Given this list of marker genes Glcci1, Hipk2, Rgs7bp, Smarca1, Cd3g, Apbb2, Pim3, Slain1, Abca1 (NCBI Gene Id 11303), Kpna4, Epx, Slitrk2, Trim30d (tripartite motif-containing 30D), Hadhb, Naa15, Vcan, Pim1, Slc7a14, Zscan22, Tmem71, Xrcc2, Tnfaip3, Crot, Six4, Nr1i3, Lrrtm4, Clec2i, Lrriq3, Zfp81, Arhgef7, Mlxip, Usp32, Ebf1, Rnase10, Nol11, Itgae, Epha8, Tbx22, Galnt13, Spry1, Top2a, Srek1, Kcns3 (potassium voltage-gated channel, delayed-rectifier, subfamily S, member 3), Invs, Sntg1, Dcun1d5, Ahrr, Rfx3, Eef1a1, Satb2, Lama3, Slc5a12, En2, Cdc42bpa, Hmga2, Mapk4, Ywhah, Pdgfra, Tph2, Esco1, Kcnd3, 4930426D05Rik, Tom1l1, here is a description of the gene set: from publication Chen Y, Wang X (PMID 31504780) Genes predicted to be targets of miRBase v22 microRNA mmu_miR_669g in miRDB v6.0 with MirTarget v4 prediction scores > 80 (high confidence targets). species: Mus musculus Mouse Gene Set: MIR_669G